The following is a description of a gene set: The process, occurring in the embryo, by which the anatomical structures of the appendage are generated and organized. An appendage is an organ or part that is attached to the trunk of an organism, such as a limb or a branch. Human Gene Set: GOBP_EMBRYONIC_APPENDAGE_MORPHOGENESIS species: Homo sapiens, and this is the list of marker genes: SHOX2 (NCBI Gene Id 6474), B9D1, CREBBP (NCBI Gene Id 1387), OSR1, HOXC10, SKI, INTU, NIPBL, GREM1, TGFB2, GLI3, CHD7, NOTCH2, MUSTN1, HOXD10, FBN2, SMAD4, ZBTB16, GPC3, NOTCH1, TFAP2A, SFRP2, CTNNB1, MSX1, TBX5, WDPCP, C2CD3, RARB, DLX6, MKS1, BCL2L11, WDR19, TRAF3IP1, GNA12, SP8, MOSMO, MED1, PBX1, ALDH1A2, BMP7, IFT52, TMEM107 (transmembrane protein 107), SHH, BPNT2, DKK1, FREM2, PRRX1, TTBK2, IHH, HOXA11, WNT3, TMEM231, PITX1, ACD, WNT7A, FLVCR1, TBX2, TBX4, IFT122, FRAS1, ZNF358, NOG, PBX2, ECE1, HOXD9, RSPO2, ALX3, DYNC2H1, RDH10, PITX2 (NCBI Gene Id 5308), MYH3, GJA5, SP9, PRICKLE1, BAX (NCBI Gene Id 581), TBC1D32, WNT5A, HOXC11, AFF3, LRP5, LEF1, LRP4, TP63, HOXA13, RECK, FGF4, BMPR1A, TBX3, TULP3, MYCN, RUNX2, ALX1, LNPK, OSR2, PTCH1, HDAC2, FBXW4, GRHL2, MSX2, FGF8, CRABP2, LMBR1 (NCBI Gene Id 85501), SALL1 (spalt like transcription factor 1), CHST11, CYP26B1, RARG, TWIST1, CACNA1C, ALX4, BMP4, HDAC1, HOXA9, FGF9, FGFR1, HOXD12, RPGRIP1L, FZD6, HOXA10, IFT140, PSEN1, DLX5, GDF5, SALL4, HAND2, MAP3K20, HOXD13, MEGF8, EN1, MBNL1